Given this list of marker genes FBXO8, DDX55, ZNF678, PAG1, TFAM, SELENOI, GBP2, FBXO43, ACER3, YTHDF3, MFAP2, B4GALT4, USP13 (NCBI Gene Id 8975), ZMPSTE24, NPM1 (NCBI Gene Id 4869), RP2, TM2D3, SPOCK3, CYP24A1, ZNF468, PLD5, CDKN1C, CCNA2, GSPT1, TTYH2, NIN, STAM2, ADGRL2, TGDS, MBNL1, TC2N, UBXN4, C21orf91, ANKRD13C, CCDC102B, ABHD13, LIN7C, TVP23C, SLC25A36, ZNF326, SAMD8, GTF2I, AKAP1, ACTR3B, REDIC1, GPR155, CYP4V2, SMARCA5, RNF180, FKBP5, G3BP1, DSG1, TIAL1, ZNF382, FZD1, BEND4, QKI, GNL3L, INPP4A, DPP8, DCLK1, C15orf40, APPBP2, NAB1, FAM241A, B4GALT6, KLHL15, CYP2U1, KANSL1, SRD5A1, NWD2, NET1, ATL3, USP25, SINHCAF, SLC38A1, SLC12A2, SETBP1, PEX5L, BNIP2, NUFIP2, TSC22D2, AKR1D1, PPAT, NANOGNB, INO80D, ANGPTL1, TBC1D22B, MDFIC, SLC19A2, DENND1B, CDK17, FLRT2, DNMT1, DBI, GABBR2, SPIRE1, ARL14EP, HOXD13, PSD3, MMGT1, PELI1, KLHL24, LPCAT2, MED13L, FBXL20, NAA15 (NCBI Gene Id 80155), C5orf24, EVI5, MAP3K2, ZNF740, RBM47, PHIP, ATXN1, HPS1, ITGAE, PDE10A, PSIP1, ANO4, FAXC, RASEF, ROBO1, CBLL1, ZBTB2, MOSPD1, NAPG, PTPN5, EXOSC9, FAT1, SP4, AGO2, TRUB1 (TruB pseudouridine synthase family member 1), PLEKHM3, AMER2, GTF2A1, STK24, EREG, PTH2R, NABP1, EFEMP1, CREB1, BNIP5, COA5, IQGAP2 (IQ motif containing GTPase activating protein 2), SUZ12, KMT2D, MARCHF4, ELAVL1, TNPO1, HDAC4, TAOK1, PCDH11X (protocadherin 11 X-linked), FBXO11, ZEB2, UHMK1, PIK3CA, SLC9A1, HDAC9, ARID1A, ARGLU1, AP1AR, RIT2, TRHDE (NCBI Gene Id 29953), XRN2, IGFBP3, TP53INP1, DNAJB5, NFU1, ASAP2, STRA6, DAG1, AZIN1, GK5, DHX32, CIP2A, SGMS1, ZBTB24, PPP1R16B, TMEM41B, IGSF5, SH3GLB1, SFPQ, AEBP2, APPL1, ATP2B4, SOX21, RPRD1A, SERPINB1, STOX2 (NCBI Gene Id 93007), MTCL3, OSBPL8, GTF3C4, SOS2, CCNYL1, BPNT2, EGR3, KLF8, PFKFB2 (6-phosphofructo-2-kinase/fructose-2,6-biphosphatase 2), UFM1, PRKAR1A, SIAH2, TM7SF3, GPC4, INSYN2A, YBX1, C12orf75, FAT4, RPS6KA3, PXDN, ANKH, ICE2, COL4A1, MAF, PPP4R2, SYNCRIP, CD38, UBAC2, CSNK2B, AAK1, BCOR, ACSL3, RALYL, SOAT1, SLC2A13, RSPRY1, SLC25A30, HMGN1, NFYA, MAP2K4, NEXMIF, SLC17A2, SNX16, SEC62 (NCBI Gene Id 7095), MED1, PTBP2, SOX6, CRY1, QTRT2, PPP6C, GABRB2 (NCBI Gene Id 2561), PIK3R3, MARCHF5, HERPUD2, ZNF334, HYCC1, CNTNAP2, MSTN, CARTPT, ADISSP (adipose secreted signaling protein), WNT5A, KANSL1L, L2HGDH, ZFP30, UGGT1, SNW1, TRIP12, KLHL5 (NCBI Gene Id 54163), MED30, MPZL1, DDA1, GKAP1, FHDC1, GNB4, STAG2, PBX1 (PBX homeobox 1), VPS4B, ZNF568, AFAP1, LARP4, SLC23A2, BPTF, SH3TC2, ZDHHC21, UBXN2B, RPL34, GNE, TIGD3, TFDP1, PDE1A, NOVA1, SLC25A16, FRMD5, FAM171B, DICER1, SCYL2, CLGN, COPS2, NAA50, PRKAA2, CCZ1, BCLAF3, STRBP (spermatid perinuclear RNA binding protein), SLC7A11, AICDA, GCLC, REV1, NOTCH1, ZNF20, SPTSSA, TBP (NCBI Gene Id 6908), SNX18, GABRB3, JADE3, MIB1, SLC16A7, IRAK2, MBNL3, RBBP9, SHPRH, DAZ4, IFT56, PARP15, SUB1, KDELR1 (KDEL endoplasmic reticulum protein retention receptor 1), SYT4, BMP3, KDM7A, DPP10, NLGN1, FARP1, UBE2D1, NRIP1, MYNN, MDM4, PIK3IP1, PSMD11, GPATCH2, SEC16B, WNK3, SAR1B, TGS1, ADGRE2, ST6GALNAC5, ABCC5, EEF1A1, RIMKLB (ribosomal modification protein rimK like family member B), RNF19A, TFPI2, EMC1, HOXA5, MAPKAPK2, FLI1, ATF7IP, VEZF1, IRX2, CDYL, XRN1, SUFU, GPC6, ZNF322, ZCCHC14, TMEM50A, CECR2, ZDBF2, HDX, SMIM8, CRISP1, CYP8B1, TXNRD3, GAB1, TMPRSS11F, ZNRF2, AGPS, ADNP, CCZ1B, MED13, BRD10, BCAP29, PALM2AKAP2, ARFGEF3, MORC3, FERMT2, PPFIA1, MBTD1, RBMS3, LPP, BLOC1S2, SLC25A44, BTAF1, ANLN, SLC30A7, ACBD5, BACE1, ARL6IP5, TMEM170A, THSD7B, CDK6, PTPRZ1, DAZ2, DUSP15, IPMK, CNEP1R1, SOX2, SLC35D1, RAB40B, AMFR, SMURF2, SON, DCBLD2, C16orf46, MED6, OSTM1, MBOAT2, PDS5B, MICU3, PHACTR2, NUP62CL, PCDHB15, DCDC2, YES1, ANO5, GNG2 (G protein subunit gamma 2), PHF20L1, RBBP4, CD47, TET2, ZNF280D, VCPIP1, CNBP, EYA3, SLC7A2, TMEM64, YWHAZ, SBSPON, PUM2, MCTS1, IGFBPL1, SIDT2, ZDHHC17, LRATD2 (LRAT domain containing 2), TCF7L2, MANEA, ZNF750, ATRNL1, FSBP, ZNF367, AFF1, SKAP2, CADM2 (cell adhesion molecule 2), SOCS6, KNTC1 (NCBI Gene Id 9735), VKORC1L1, PSMA1, XYLT1, ROR1, DAZ1, PPP3CA, ZBTB44, PGR, BAG5, PAPOLA, OAS3, USP10, USP38, PURG, PRSS35, HNRNPF, KCNQ5, KIAA0586, YIPF6, SSU72, TMCC3, ZNF704, PRKCA, PLAGL2, TLNRD1, IGF2BP3, TNRC6B, GORAB, PPM1K, ABLIM2, MED12, DIS3L2, PLEKHB2, DIP2B, USP15, G2E3, PM20D2, ARHGAP45 (Rho GTPase activating protein 45), LNX1, MAFG, ALG10B, YTHDF1, RBBP8, DNMT3B, NHLH2, DYRK1A, ZNF236, BDP1, SLCO5A1, HECTD2, RBM27, ASPH, ARID4A, NEK7, BTBD7, CARF, SECISBP2L, PPP1CC, FOS, ZNF562, IDE, CCND1, MPHOSPH9, ANKRD28, MARK1, ETNK1, PRMT1, DAZ3 (NCBI Gene Id 57054), ZNF652, DYNC1LI2, DEPDC1B, FGFR3, SPON1, ANKIB1, GJA3, PIGN, ZMYM3, UBE2W, NPM3, TBL1X, LIN28B, MAP2, ALCAM, GLCE (glucuronic acid epimerase), SLC10A4, SHISAL1, PPP2R2B, RANBP1, ABCD4, RRP15, RAC1, EIF4B, KCNJ2, PDE7A, MAPK8, SOCS5, TMED4, CTDSPL2, SACS, CNOT6L (NCBI Gene Id 91275), LLGL2, WASF1, CNST, SMIM13, ACVR1C, RSBN1, RIMS1, DPY19L1, PCGF5, TMEFF2, MEX3B, SMC2, VAPA, GFPT1, RHOQ, ZEB1, KLHL28, COL1A1, AAGAB, ZNF681, RAB23, GPD2, SOST, ZNF24, ZBED4, RAD54B, ADGRB3, STARD4, ZYG11B, TBL1XR1, EPC1, CTNND1, GTDC1 (glycosyltransferase like domain containing 1), CCNT1, USP42, INPP5F, ING3, RNF217, USP46, B3GALNT2, LIN7A, ZNF264, PPP2R5E, TSPAN9, FBXW2, PTPRD, RPS6KA6, ERBIN, CPD, ZFHX3, VPS13C, NAMPT, ORC4, WDR44, ACVR2B, MME (NCBI Gene Id 4311), APH1A, VGLL3, FGD6, B3GAT1, DCUN1D4, AVL9, VASP, ZNF561, MOB4, PKD2, CPNE8, SKI, XPR1, ST6GAL1, SGMS2, FBXL17, SHROOM3, RNF139, DLEU7, GNAI1, SEMA6D, CREBRF, TRPC1, UTRN, RBM12B, CNKSR2, ACVR1, ERGIC2, TOP1, HOOK3, PLPPR4, HOXA9, USP49, TLL1, EIF5A2, HNRNPR, ZC3H12C, FRS2 (NCBI Gene Id 10818), MAP4, ARK2N, PUS7, MOCS2, CFAP61 (cilia and flagella associated protein 61), NSD2, GTF2B, AFF3, RORA, ADH7, CREBBP, TET3, NTN4, DDX4, RPS3, ZNF148, PYGO1, ZBTB41, FAM83B, PRKCB, AOX1, DUS4L, MMD, TUT4, C17orf58, CXCR4, MARCKSL1, FYN, SYT1, NCOR1, SNRPD1, RB1, LZIC, DTD1, DACT1, MMADHC, ATXN2, OTUD7B, LIG4, ELOVL4, B3GALT2, MCC, ITPRIPL2, PHC3, GSE1, RECQL, RBPJ, ARFGEF1, EPG5, H1-8, DCAF17, ARL5A, ARHGAP39, CNOT7, PCDH20, SCAI, CPEB3 (NCBI Gene Id 22849), CPSF6 (NCBI Gene Id 11052), TOX, TLDC2, MCF2L2, COQ10A, ABHD2, DCAF12L1 (NCBI Gene Id 139170), HBEGF, DMRTA1, OXGR1, PDE4D, CDKN1B, ARL6IP6, HOXA3, KMT2A, SEH1L, UBR5, ABI1, TRIM36, ZSWIM6, ELMOD2, PRRC1, PNISR, FOXP2, PPP4R3A, KLHL11, ERBB2, UBN2, SLC4A7, CALCRL, CKAP2, KPNA4, CCDC71L, SCG2, TRIM33, TOX3 (NCBI Gene Id 27324), PHF14, MEF2C, PRMT3, DPY30, OAF, C4orf51, NAP1L1, ATOSA, ETS1, PARD3, MRPS11, DCK, CAMTA1, GGCX (NCBI Gene Id 2677), YIPF4, SKIL, KCMF1, ZNF609 (zinc finger protein 609), FOXN2 (forkhead box N2), SRFBP1, MOB1B, BCAT1, SGCB, COMMD9, CELF2, DLG1, PTPDC1, ANKS1A, N4BP2L2, FYB1, FER, PRPF6, GPR63, ATF1, SERINC3, NOTCH2, AGR3, FAM169A, GABPB1, ZNF493, PIK3R1, PDE1C, ESRP1, TJP1, ABCA5, LEMD3, KRAS, GABRG1, DNAI4, PTPRK, LHX9, P3R3URF-PIK3R3, C2orf49, LRRTM4, SMC5, MOSMO, SREK1IP1, TMPRSS11D, SSH2, RBM24, ADAM17, CCDC73, KIAA1210, RAF1, ZFAND5, JAK2, HMGXB4, ZNF800, EIF1AY, CSNK1A1, MATR3, NOL4, AKAP5, PRKCI, SLC18B1, KCTD12, MTSS1, DNAJC19, ZNF469, TMEM135, GAS1, RAB3C, MYEF2, RGS13, SLC4A10, SCN9A, TVP23B, MCU (mitochondrial calcium uniporter), TAF5, TMPO, RANBP3L, ATP2A2, NTF3, SASS6, MYBL1, ARHGAP29, MAPK6, ARHGAP32, PROSER1, FGF12, PAK2, AHSA2P, NSL1, ZNF706, IKZF2 (IKAROS family zinc finger 2), PAN3 (NCBI Gene Id 376186), KIAA0232, AGBL3, FGFR1OP2, FAM220A, WDR37, PTBP3, HIF1A, SPICE1, ERLEC1, DCP1A, ETF1, HIPK2, GRIA2, MKRN3, CCL3L3, ZNF28, KIAA0408, DYNLT3, NR2C2, NSMCE3, GABRA4, HYCC2, ICAM5, USP53, ARAP2, FMNL2, MAFB, CLSTN1, CPEB4, RYK, ZNF682, DYRK2, TMED2, GNAI3 (NCBI Gene Id 2773), TTC14, MCL1, TIA1, NKX2-1, FYTTD1, ERO1B, CPEB1, BCAR1, ATF6, USP24, TMCO1, CFLAR, PLAC8L1, STRN3, DIMT1, RC3H1, DTNA, RNGTT, USP37, FZD3, FAM177A1, CLDN11, TGFBR1, MINDY2, KLB, UBE2H, SERTAD2, FOXJ3, MYC, TOMM70 (NCBI Gene Id 9868), ZFR (zinc finger RNA binding protein), CREM, CDC5L, PDS5A, SORBS1, PLAT, SUGT1, MCTP1, LCOR, MAML3, KDM5B, LSM8, ASNSD1, CAMSAP2, ZNF365, here is a description of the gene set: Genes predicted to be targets of miRBase v22 microRNA hsa-miR-548aj-3p, hsa-miR-548x-3p in miRDB v6.0 with MirTarget v4 prediction scores > 80 (high confidence targets). studied in species Homo sapiens Human Gene Set: MIR548AJ_3P_MIR548X_3P from publication Chen Y, Wang X (PMID 31504780)